The following is a description of a gene set: Human Gene Set: HP_ABNORMAL_EYELASH_MORPHOLOGY An abnormality of the eyelashes. Abnormal eyelash morphology studied in species Homo sapiens, and this is the list of marker genes: BLM, NAA10, POLR1C, CAMKMT, SLC30A9, PUM1, TBCK, EP300, DPH1, VPS33A, PUS1, LTBP1, B4GALT7, FAM111B, RAC3, CANT1, TUBGCP4, RPL21, ODC1, GNB2, XYLT1, CST6, DOLK, RPS23, SMC3, EDAR, CTC1, FZD2, SMAD4, ITGA3 (NCBI Gene Id 4454), CHMP1A, COL11A1, KANK2, C1GALT1C1, VAC14 (VAC14 component of PIKFYVE complex), SPEN, YARS2, HCCS, EDNRB, ZNF699, EDARADD, DVL3, DEPDC5, NECTIN4, WDR35, COX5A, KRT74, ARID2, EDN3, SF3B4, DOCK7, RNU4ATAC, HPDL, FGF5, SHANK3, BMP1, FRAS1, TSR2, ASCC3, KCNH1, MOGS, CSGALNACT1, TWIST2, RNU12, EDNRA (endothelin receptor type A), HECTD4, USB1, LIPH, MBD5, DSC3, TAF6, PREPL, POLR1D, CHD6, IRX5, FGF10, COX7B, DSP, LSS, SOX4, ARID1B, GJB6, TYRP1, GJA8, OCA2, KDM6A, KRT83, KRT81, RNU4-2, HRURF, COL3A1, ANTXR1, CDH1, DVL1, HOXC13, CTCF, ST14, LPAR6, FBXO11, STAG2, VPS51, MADD, RNF2, PARN, JUP, FOXC2, PNPLA6, POLR1B, DPH5, VARS1, SHOC2, TERT, ZFX, SMARCD1, SLC25A24, PPM1B, WNT10A, ALX1, SNRPE, BICRA, ASXL2, TERC, FGFR1, SNAI2, SOX10, LMNA, SLC3A1, BRAF, EBP, CHD1, PLCD1, WRAP53, VPS13B, SMC1A (NCBI Gene Id 8243), KRT86, NOTCH2, RTEL1, H4C5, LMNB1, KRT25, NIPBL, EPS8L3, LTBP3, PACS1, BANF1, AP3B2, RHOBTB2, RMRP, NRCAM, PLK4, NDUFB11, CWC27, BRD4, HID1, KMT2A, MED27, KCNK4, TMCO1, TYMS, HR, APCDD1, AFF4, HDAC8, DPYD, KCNJ8, TP63, MAP2K2, ABCC9, EXOC8, ASXL3, SMARCB1, PAX3, EGFR, NXN, UROS, ALX4, TAF1, FIG4, MITF, SRCAP, ARHGEF2, CDC42BPB, GJA5, TINF2, PTPN22, AXIN2, POLR3A, SMARCA2, CNOT2, MC1R, KRT71, CDSN, RAD21, TBX4, SLC4A10, DPF2, FAS, ATP6V1B2, SEC31A, MBTPS2, DHCR7, GTPBP2, ESAM, PRR12, GJB2, CLDN1, TUBGCP6, CTNND1, KRT85, NF1, PHGDH, SMARCE1, RIPK4, MLPH, KREMEN1, FBXL4, DSG4, PUF60, DENND5A, KCNN3, KIT, ANAPC1, KMT2D, GATA1, OTUD6B, RECQL4, GJA1, KRAS, CAMTA1, HSPG2, SOX18, SPINK5, UROD, TENT5A, KIF11, TIMM50, MAN1B1, MAB21L2, CDH3 (cadherin 3), CCDC47, ROR2, ARID1A, WNT5A, CLP1, MAB21L1, FBN1, PGM2L1, RECQL, SOX11, DRG1, EDA, PYCR2, MAF, ORC1, LTV1, SLC6A9, DDB1, UFC1, NOP10, PKP1, RUSC2, NCAPG2, SPOP, BRCA1, TRPS1, ACTB, MYO5A, KCNK9, DKC1, CSF1R, CREBBP, SATB2, NHP2, CNTNAP2, DLX4, MGAT2, NECTIN1, LRP1, FRMD4A, MPLKIP, NPM1, SMARCC2, SMARCA4, MAP2K1, ZMPSTE24, STAG1, SMOC1, TCOF1, SLC35C1